The following is a description of a gene set: Any process that modulates the activity of the enzyme phospholipase A2. studied in species Mus musculus Mouse Gene Set: GOBP_REGULATION_OF_PHOSPHOLIPASE_A2_ACTIVITY, and this is the list of marker genes: Ang5, Plaa, Agtr1a, Lrp1, Agtr1b, Ang6, Avpr1b, Pla2r1, Ang2, Ang, Ang4